The following is a description of a gene set: studied in species Mus musculus Mouse Gene Set: GOBP_DNA_STRAND_ELONGATION_INVOLVED_IN_DNA_REPLICATION The process in which an existing DNA strand is extended by activities including the addition of nucleotides to the 3' end of the strand, complementary to an existing template, as part of DNA replication., and this is the list of marker genes: Pole, Gins1, Mcm4, Pold2, Pold3, Mcm7, Lig1, Dna2, Pcna, Mcm3, Pole3, Pola1, Lig3